Given this list of marker genes FGF10, here is a description of the gene set: <p>During embryonic development in mammals, mammary stem cells (MaSCs) are derived from embryonic non-neural surface ectoderm. Embryonic ectodermal cells first produce epithelial cells of the mammary ridge in humans, which likely correspond to epithelial cells of the mammary placode in mice. However, as intermediary cell states during human mammary gland development have not been immunohistochemically characterized, and as direct extrapolation from findings in mouse may not be justified, only non-neural surface ectoderm cells and MaSCs have been included in this lineage and the intermediary states will be included as the data becomes available.</p><p>MaSCs have been studied in detail in mouse development, and have been much less characterized in humans. In the mouse, MaSCs are defined as those cells that are able to generate a functional mammary gland when transplanted in vivo, but there is evidence that expression of certain markers in mouse MaSCs changes during different stages of mammary gland morphogenesis e.g. during pregnancy. Most data available on human MaSCs is derived from adult stem-like cells in human mammary glands that are able to differentiate in vitro into both myoepithelial and ductal (luminal) epithelial cells and thus are also known as mammary bipotent progenitors (MBiPs). It is uncertain how much these adult human MaSCs/MBiPs differ from embryonic and fetal MaSCs. Multiple reports agree on MaSCs residing within the basal epithelial cell subpopulation in both humans and mice, but the definitive list of markers that can be used to isolate pure MaSCs from within the basal epithelial subset has not been defined.</p><p>Mouse MaSCs are first apparent in mammary placodes. Lef1 (Lymphoid Enhancer Binding Factor 1) is a transcription factor that binds to beta-catenin (Ctnnb1) after activation by Wnt/β-catenin signaling. The Lef1:Ctnnb1 complex plays a critical role in controlling the transcription of genes involved in mouse mammary placode formation by driving epithelial cell proliferation and differentiation during the early stages of mammary gland development. WNT ligand Wnt10b plays an important role in the embryonic stages of mouse mammary gland development, including placode and bud formation. Besides Wnt10b, Wnt6 and Wnt10a are also implicated in mouse mammary bud formation. Wnt4 plays a role in mouse mammary gland development during puberty and pregnancy. Wnt4 expression is regulated by progesterone, as it is expressed in progesterone receptor-positive cells, and it acts as a paracrine mediator of progesterone signaling in the mammary gland. FGF signaling also plays a role in mammary placode formation, in particular Fgf10-mediated activation of Fgfr2b, but the FGF receptor Fgfr1 and ligands Fgf4, Fgf8, Fgf7, and Fgf17 are also expressed in the developing placode. Other signaling pathways studied in mouse that contribute to development of mammary glands and maintenance and differentiation of MaSC include Hedgehog signaling, NOTCH signaling, and estrogen and progesterone signaling. The involvement of FGF10 in generation and maintenance of MaSCs appears to be conserved in humans.</p><p>In normal adult human breast epithelium, mammary stem cells are rare and are located in the ductal part of terminal ductal lobular units.</p><p>Recent studies indicate that the MaSC/MBiP cell population is heterogeneous, and it is likely that both early and late MaSCs exist with not completely overlapping sets of markers.</p> part of: Developmental Lineages of the Mammary Gland species: Homo sapiens Reactome Pathway: Developmental Lineage of Mammary Stem Cells